Given this list of marker genes BLVRA, SLCO1B3, UGT1A4, ABCC1 (ATP binding cassette subfamily C member 1 (ABCC1 blood group)), HMOX1 (heme oxygenase 1), SLCO1B1, BLVRB, AMBP, HMOX2, SLCO2B1, ABCC2, here is a description of the gene set: The chemical reactions and pathways resulting in the breakdown of a pigment, any general or particular coloring matter in living organisms, e.g. melanin. Human Gene Set: GOBP_PIGMENT_CATABOLIC_PROCESS studied in species Homo sapiens